Given this list of marker genes ITGA4, TRIB1, PMS2P3, P2RX5, CAPN2, HPGDS, FZD6, TRDC, LDLRAD4, PRR5L, IKZF2 (NCBI Gene Id 51173), TUBB6 (tubulin beta 6 class V), B4GALT6, KLF2, CD7, RAB13, HPS4, UGT2B11, NDFIP1, LRP10 (NCBI Gene Id 26020), CFD, IL4R, TSPAN7, DTX2P1-UPK3BP1-PMS2P11, CYFIP1, YBX3, ABCB1, DRAM1, TRAT1, CTNNA1, here is a description of the gene set: Top genes from cluster 4 of acute myeloid leukemia (AML) expression profile; 87% of the samples are FAB M1 subtype, 53% bear mutations in CEBPA. Human Gene Set: VALK_AML_CLUSTER_4 BACKGROUND: In patients with acute myeloid leukemia (AML) a combination of methods must be used to classify the disease, make therapeutic decisions, and determine the prognosis. However, this combined approach provides correct therapeutic and prognostic information in only 50 percent of cases. METHODS: We determined the gene-expression profiles in samples of peripheral blood or bone marrow from 285 patients with AML using Affymetrix U133A GeneChips containing approximately 13,000 unique genes or expression-signature tags. Data analyses were carried out with Omniviz, significance analysis of microarrays, and prediction analysis of microarrays software. Statistical analyses were performed to determine the prognostic significance of cases of AML with specific molecular signatures. RESULTS: Unsupervised cluster analyses identified 16 groups of patients with AML on the basis of molecular signatures. We identified the genes that defined these clusters and determined the minimal numbers of genes needed to identify prognostically important clusters with a high degree of accuracy. The clustering was driven by the presence of chromosomal lesions (e.g., t(8;21), t(15;17), and inv(16)), particular genetic mutations (CEBPA), and abnormal oncogene expression (EVI1). We identified several novel clusters, some consisting of specimens with normal karyotypes. A unique cluster with a distinctive gene-expression signature included cases of AML with a poor treatment outcome. CONCLUSIONS: Gene-expression profiling allows a comprehensive classification of AML that includes previously identified genetically defined subgroups and a novel cluster with an adverse prognosis. from publication Valk PJ, Verhaak RG, Beijen MA, Erpelinck CA, Barjesteh van Waalwijk van Doorn-Khosrovani S, Boer JM, Beverloo HB, Moorhouse MJ, van der Spek PJ, Löwenberg B, Delwel R (PMID 15084694) studied in species Homo sapiens